The following is a description of a gene set: Signaling by FGFR in disease studied in species Homo sapiens Human Gene Set: REACTOME_SIGNALING_BY_FGFR_IN_DISEASE, and this is the list of marker genes: FGF17, FGFR1, FGF3, HRAS, CEP43, FGF9, FGF7, FGFR4, FGFR1OP2, GAB1, POLR2D, POLR2L, GRB2, ERLIN2, TRIM24, STAT5A, CPSF6, FGF8, POLR2E, STAT3, GTF2F1, FGF20, PLCG1, POLR2C, FGF18, PIK3CA, SOS1, LRRFIP1, POLR2I, POLR2F, FGF2, FRS2, POLR2H, KRAS, GAB2, POLR2A, CUX1, GTF2F2, FGF5, FGF4, NCBP1, FGFR3, BCR, POLR2K, STAT5B, ZMYM2, POLR2J, NCBP2, FGF16 (fibroblast growth factor 16), POLR2B, FGF10, PIK3R1 (NCBI Gene Id 5295), FGF23, FGF22, FGFR2, MYO18A, NRAS, CNTRL, FGF6, BAG4, FGF1, POLR2G, STAT1